Given this list of marker genes Acvr2a, Setdb2, Nodal, Pcsk5, Ctnnb1, Enkur, Gas8, Dnah11, Dnah5, Cep290, Odad2, Smad2, Ift74, Aldh1a2, Ihh, Lbx1 (ladybird homeobox 1), Nek8, Tbc1d32, Grem2, Ccdc39, Rnf207, Foxh1, Cfap45, Aplnr, Dll1, Acvr1, Asb2, Nme7, C2cd3, Kif3a, Nkx3-2, Pkd2, Anks6, Tmed2, Psen1, Sostdc1, Dnaaf4, Invs, Tbx20, Map3k4, Fgf8, Vangl2, Gata4, Ovol2, Dpcd, Mib1, Dnaaf1, Tmem67, Ift140, Lefty1, Nat8f5, Dnai1 (NCBI Gene Id 68922), Galnt11, Odad3, Dand5, Ripply2, Rpgrip1l, Wnt5a, Dnaaf11, Pierce1, Mesp1, Ccdc103, Cfap52, Cfc1, Nkx2-5, Tbx3, Megf8, Mks1, Mapk8, Ap1b1, Dnaaf2, Pcsk6, Ift57, Zic3, Mmp21, Ccdc40, Pierce2, Cripto, Smad3, Tgif1, Folr1, Hand1, T, Hif1a, Dvl2, Cited2, Arl13b, Daam2, Ift172, Pskh1, Drc1, Notch2, Hand2, Pitx2, Rttn, Tbx2, Rfx3, Odad4, Alg5, Wnt3a, Acvr1c, Nphp3, Pkd1l1, Cc2d2a (coiled-coil and C2 domain containing 2A), Daw1, Nbl1, Foxf1, Smo, Mef2c, Dvl1, Cirop (NCBI Gene Id 101056084), Srf (NCBI Gene Id 224821), Foxn4, Lrp6, Sox17, Acvr2b, Dnaaf3, Gm572, Kdm2a, Dync2h1, Tmem107, Stil, Rbpj, Shh, Dnai2, Eng, Foxj1, Ift88, Cfap53, Ddit3, Aida, Dync2li1, Grem1, Gja1, Tbx1, Sufu, Cluap1, Cer1, Disp1, Notch1, Fgf10, Tgfbr2, Ofd1, Bicc1, Zic2, Ift52, Noto, Mical2, here is a description of the gene set: species: Mus musculus The establishment of an organism's body plan or part of an organism such that a similar arrangement in form and relationship of parts around a common axis, or around each side of a plane is created. Mouse Gene Set: GOBP_SPECIFICATION_OF_SYMMETRY